The following is a description of a gene set: Genes up-regulated in comparison of SP1 thymocytes versus SP3 thymocytes. species: Homo sapiens After positive selection in the thymus, the newly generated single positive (SP) thymocytes are phenotypically and functionally immature and undergo apoptosis upon antigen stimulation. In the thymic medullary microenvironment, SP cells progressively acquire immunocompetence. Negative selection to remove autoreactive T cells also occur at this stage. We have defined four subsets of CD4 SP, namely, SP1, SP2, SP3, and SP4 that follow a functional maturation program and a sequential emergence during mouse ontogeny.We used microarray to detail the global programm of gene expression during the maturation of murine CD4 single positive thymocytes from publication Teng F, Zhou Y, Jin R, Chen Y, Pei X, Liu Y, Dong J, Wang W, Pang X, Qian X, Chen WF, Zhang Y, Ge Q (PMID 22022412) Human Gene Set: GSE30083_SP1_VS_SP3_THYMOCYTE_UP, and this is the list of marker genes: CCR1, UQCC2, RAPSN, HEY1, CCL5, ITM2A, PRR32, TRIAP1, SPRYD4, PKIB, PAXBP1, SPTY2D1, HIVEP2, HIVEP3, KRTAP4-7 (keratin associated protein 4-7), MMP9, ABHD17C, SLC37A3, PTTG1IP, MRPS30, APEX1, ARMCX6, TCF7L2, SLC3A2, TXN2, TIMM22, PNLIPRP1, YES1, CHL1, PON3, HFE, CCR8, GET1, MAPK6, HLA-DOA, TTLL11, NFKBIB, GTPBP4, MRPL4, EIF3C, NOP2, TCF4, CRABP2, IFITM3, NUDT15, SPRED1, BOD1, HS1BP3, DUSP1, ST3GAL2, PWP2, TNFRSF9, NDUFB2, IER5, MRPL54, TFRC, SLC35D3, RAD23A, FAR1, CCDC86, LAMA3, PRKCD, PRDX5, COPS8, TPK1, TUSC3, SLC5A6, SLC7A6, HSD17B12, DUSP5, EXT1, WDR74, MYO3A, MAGED1, MAST4, COBLL1, WDR70, ETV5, GPS1, SUPV3L1, SF3B5, TUBA1A, CRY1, ZNHIT1 (NCBI Gene Id 10467), VPS72, OTUD6B, PIP4K2A, SLC35B1 (solute carrier family 35 member B1), SYTL2, CD81, GET3, ZMPSTE24, ITK, UQCR11, C8orf82, C1QTNF12, LAD1, RPE65, GPX4, CCL25, MTF2, CBX8, GPR153, TAF7, LMO2, NDUFA11, POLR2E, PHPT1, PPAN, GPR137B, XBP1, REC8, UBTD2, AMN, VPS18, NUCB1, TRIB1, IPO4, TNIP2, NAT10, HMGN3, GNAL, EXPH5, CYP24A1 (cytochrome P450 family 24 subfamily A member 1), NFKBID, C19orf53, GOT1, HHAT (hedgehog acyltransferase), FAM110B, CIMAP1B, TSC22D1 (NCBI Gene Id 8848), PDCD1LG2, ZNF879, TMBIM4, ZNRD2, SOST, KNOP1, THBS4, ATP23, KLF10, HNRNPDL, TFPI, IZUMO1R, STX11, TIMM29, ABT1, CALB1, ABCB4, TTC21B, LCMT1, ZNF821 (zinc finger protein 821), LHFPL2, CFAP97D1, CAMSAP1, BAG4, JUNB, ADAM9, FTL, WDR4, C5orf15, FABP5, RAB8B, KCNK1, GCA, DRAM1, LAMC1, PISD, CLPP, ASB2 (ankyrin repeat and SOCS box containing 2), TAF11, ATCAY, SMARCE1, TEX22, IL1RAPL2, RPRM, TSR2, SAR1A, TMEM176B, ARMCX5, TSPAN31, ATF6, MMD, NUFIP1, CNN3, NECAP1, NEDD4, DIPK1B, UTP4, ZNF608, CAMK2D, PENK, BEND7, RNF130, N4BP2L2, MRPS28, TIMM13, CCT3, IFI27, SFXN2